The following is a description of a gene set: from publication Chen Y, Wang X (PMID 31504780) Genes predicted to be targets of miRBase v22 microRNA hsa-miR-4753-5p in miRDB v6.0 with MirTarget v4 prediction scores > 80 (high confidence targets). Human Gene Set: MIR4753_5P studied in species Homo sapiens, and this is the list of marker genes: PLPP3, RAB21, PGAP2, ANKFY1, RAB5B, FLI1, RBPJ, NUFIP2, TCF12, XYLT1, SPTLC2, GNAQ, BCLAF3, CYLC1, BRWD3, EFHD2, VDAC2, SDC2, ACSBG1, GNAO1, GAB1, KMT5A, PPAT, IRGQ, WDR26, USP36, ORAI1, ABRAXAS2, MFSD14A, EIF4E3, PPFIA1, ZSCAN26, ENDOD1, KCTD7, VDAC3, IQCJ-SCHIP1, MAPRE1, LARP4, STX2, IRF2BP2 (NCBI Gene Id 359948), FAM53B, CEP350, SLC25A36, NIPA2, MATCAP1, TMEM151B, ATP8A1 (ATPase phospholipid transporting 8A1), ARPP19, SPRY3, SYNJ2BP, GRID2, RCAN1, GALNT15, RNF13, CRYBG1, CHM, ARHGEF3, LMNB1, MICAL3, RHOJ, SLBP, SAP130, POLE3, FAM120C, PLEKHA6, COL19A1, SLC41A2, CKAP2, FSD1L, PDK3, TMEM164, GAS2L1, AGO1, EPHA7, QRICH1, SFRP4, RHOQ, ATP5IF1, AGFG1, PTPRE, ST3GAL3, RHOBTB1, KIF1B, LZTS1, TDRD1, ZNF148, MAP6, ELAPOR1, KDM3B, RNF4, ZNF586, RNF212B, IGDCC4, TOX3, USP8, HDLBP (NCBI Gene Id 7426), NUMB, ZBTB20, PAX5 (paired box 5), MAP4K3, PBX3, EYA1, ADIPOR2, TEF, NEDD1, ATF7, KLHDC10, MAST4, SOCS6, NHSL3, CRTC1, MDGA1, RHOA, ATP8A2, REEP1, AFG1L, SP1, SUB1, SFMBT2 (Scm like with four mbt domains 2), MAP3K2, DYRK1A, LYSMD1, GABRB3, GFM2, LLPH, CNOT7, DBNDD1, PTBP2, PDIA6, AP1G1, AKAP13, LRP10, UNC5A, DCBLD2, CEP170, SEPTIN9, ZEB1, ABHD17B, TMEM200B, LCLAT1, CAB39, TBC1D14, MCTP2, CPNE8, FYCO1, C17orf100, ONECUT2, TCF20, SMAD4, TNRC6B, ENAH, ENY2, KMT5B, ARL8B, CUL4A, PIAS2, UNC80, GRM5, RFX1, ETS2, TRIP11, LHX6, HAND2, PJA2, PRRC2B, PISD, L3MBTL2, TENM4, BNIP3, OCRL, SLC37A4, THRB, OTULINL, MBNL3, RASEF, RASSF8, CDH11, RCOR1, B3GALNT2, RAB8B, SOCS7